Given this list of marker genes METAP1, IFI27, RHOQ, HADHA, APOD, TUBA3E, PSMB6, IGHE, ABCC9 (NCBI Gene Id 102724274), NDUFS7, ITGA9, PTPN3, IDH3B, SETD4, PFKM, SDHD, HRAS, CPT1B, ZNF330, PCDHA3, BNIP3, PDK4, SLC25A20, DECR1, PDE3A, NDRG4, ACSL3 (acyl-CoA synthetase long chain family member 3), TSFM, UQCRC1, RAPGEF2, FGF18, RCAN2, APOA1, GOT2, COPS3, NDUFS3, SPTBN1, LAMA2, PDLIM5, LMO7, POLR2F, ALAS1, HIPK3, GPT, PPFIBP1, PTPRM, HEBP2, CYB5R1, CDK2AP2, GCNT2 (glucosaminyl (N-acetyl) transferase 2 (I blood group)), UBAC1, CPVL, TJP2, PFKP, HADH, RASSF9, PYGB, HYAL1, PLA2G4C, MAOB, LDAF1, ACAA2, TOB1, COX8A, ACAT1, IPO13, PDZRN3, IMPA2, COA1, PCDH7, MYL12A, COX17, FH, UBE2L3, PAIP2B, PPP2R5C, ADH5, PLCL1, KCNQ1, GNLY, ACTN2, GATD3, SLC1A3, ACADVL, FLII, PINK1, FEM1C, ENO3, HSPB6, CDH13, RTL8C, UBE2H, SDHA, ECH1, H2BC7, CAPNS1, VPS13D, PRDX3, PHYH, MYL3, TBC1D4, TWF2, STARD7, MAPKAPK3, SGCD, KIFC3, KCNJ8, ASS1, CHN1, PTPN14, AIMP2, VPS8, PHKA1, MLH1, CDH2, CLCN1, ELAC2, SRGAP3, CD36, LPL, GLUD2, PLN, FABP3, ECI1, GADD45A, COQ9, HSPA9, GAB1, SORBS2, DLK1, MRPS18B, AUH, GABRE, VDAC1, P2RY2, COX7A2, PKIA, SDHB, KIFBP, CRADD, LARP4B, STK39, OXA1L, H1-2, MAP4 (NCBI Gene Id 4134), BCAT2, AZGP1, CDKN1C, NDUFS1, ATP1B1, H3C6, SLC5A1, C1QBP, TUBA3C, PPP2R3A, MPPED2, GCAT, H2BC21, CHN2, PCSK6, STIM1, OGDH, MEIS2, IRX5, TNNC1, MYL2, ALPK3, UQCRQ, CXADR, FHL2, PDHX, CAP2, GYS1, ATP5F1A, H2BC5, NDUFAF1, SLC22A5, ATP5F1C, ZNF710-AS1, TNNI3, CAPN2, CSRP2, CKMT2, NDUFA9, DLD, ADAM23, TCAF1, VTN, CYC1, IDH2, CCT7, ZBTB43 (zinc finger and BTB domain containing 43), SLC25A3, GBE1, UNG, NDUFV2, MAP3K5, CYB5A, DIO2, CCND2, ISCU, UBE2D1, GRM1 (NCBI Gene Id 2911), PCYT2, RAB21, AFG3L2, TNNT1, GNAS, MCCC2, WWP1, TMC6, RPL3L, BDH1, PKP2, EYA1, ARIH2, NDUFS6, MRPL33, PODXL, ALDH1L1, MYBPC3, ABLIM1, RNF10, TBX1, PDE1C, SH3GL2, ECHS1, OPA1, UBE3A, LDB3, NLGN1, GPC1, COX5A (NCBI Gene Id 9377), ALDOC, AK4, H2BC10, GRAMD1B, BCKDHA, PARP1, ZHX2, UQCRFS1, AIFM1, NUAK1, IVNS1ABP, RCAN1, BDNF, DPYSL4, LYRM1, TUBA4A, MYOM2, PDLIM1, ACADS, PGM1, AMD1, ALDH5A1, UBE2G1 (ubiquitin conjugating enzyme E2 G1), UBA3, LDHB, MMP23B, NDUFS2, ACAA1, here is a description of the gene set: from publication Kääb S, Barth AS, Margerie D, Dugas M, Gebauer M, Zwermann L, Merk S, Pfeufer A, Steinmeyer K, Bleich M, Kreuzer E, Steinbeck G, Näbauer M (PMID 15103417) To obtain region- and disease-specific transcription profiles of human myocardial tissue, we explored mRNA expression from all four chambers of eight explanted failing, and five non-failing hearts using high-density oligonucleotide arrays (Affymetrix U95Av2). We performed pair-wise comparisons of gene expression in the categories (1) atria versus ventricles, (2) disease-regulated genes in atria and (3) disease-regulated genes in ventricles. In the 51 heart samples examined, genes showed divergent distribution between atria and ventricles (genes with higher expression in atria, genes with higher expression in ventricles). Two hundred and eighty-eight genes were differentially expressed in failing myocardium compared to non-failing hearts (genes regulated in atria and ventricles, 172 regulated in atria only, genes regulated in ventricles only). For disease-regulated genes, down-regulation was 4.5-times more common than up-regulation. Functional classification according to Gene Ontology identified specific biological patterns for differentially expressed genes. Eleven genes were validated by RT-PCR showing a good correlation with the microarray data. Our goal was to determine a gene expression fingerprint of the heart, accounting for region- and disease-specific aspects. Recognizing common gene expression patterns in heart failure will significantly contribute to the understanding of heart failure and may eventually lead to the development of pathway-specific therapies. Human Gene Set: KAAB_HEART_ATRIUM_VS_VENTRICLE_DN Genes down-regulated in the ventricles of healthy hearts, compared to atria. species: Homo sapiens